Given this list of marker genes Nudt12, Slc25a22, Kmo, Kynu, Gpd2, Slc1a3, Aspdh, Nadk, Slc25a11, Nudt17, Got1, Aox1, Ldha, Nmnat3, Slc25a13, Got2, Nadk2, Slc25a51, Macroh2a1, Nmrk2, Parp14, Mdh2, Haao, Nmrk1, Qprt, Nampt, Nmnat2, Art2b, Mdh1, Afmid, Gpd1l, Gpd1, Nnmt, Slc25a18, Sarm1, Slc37a2, Ido2, Art2a, Nadsyn1, Nmnat1, Ldhb, Naprt, Ido1, Slc25a12, here is a description of the gene set: The chemical reactions and pathways involving nicotinamide adenine dinucleotide (NAD+), a coenzyme that interconverts with its reduced form, NADH, in many redox and catabolic reactions. Mouse Gene Set: GOBP_NAD_METABOLIC_PROCESS species: Mus musculus